Given this list of marker genes TAF12, PBX3, ZNF148, HEXB, TFPI2 (tissue factor pathway inhibitor 2), ID4, INPP5K, CREB1, FOXD1, MYH10, CDK1, KIF11, MGAT2, NIPAL3, ALDH7A1, CDKN1A, CSNK1A1, ABCD3, TUBB, HMGCL (3-hydroxy-3-methylglutaryl-CoA lyase), CTSL, EPCAM, KIF2C, NID1, CD9, HSPA5, KAT5, FGF9, CCNG2, ZNF711, FCGRT, ATP6V0A1, SERPINB1, CD46, CXADR, PLD3, LEPROT, MICB, SRSF3, SEC23A, GALNT3, PGRMC1, KLHDC3, TOP2A, LAMA3, H1-0, RAB6A, PCBD1, MTOR, TMED10P1, GET1, ARF6, EXTL2, PRKAR1A, TM9SF1, PTPN1, PPP6C, RAB8A, CYBA, PTCRA, PPP2R5C, NDUFA4, FSTL1, PPIC, TXNDC9, GTF2I, IGF2R, EXOC5, ACTA2, ANXA7, JAK1, TMBIM6, BNIP3, MAP2K1, ADCYAP1, RDX, IDH1, KIF5B, TMPO, NAT1, CKS2, SERINC3, NDUFS1, NEU1, COPS2, TMED10, DEK, KRT4, NFYC, ATP5PB (NCBI Gene Id 515), MAT2A, RHOC, SRSF5, QPCT, TSG101, NTS, ADD1, CAT, GUCY1B1, TIMM17A, SEPHS2, LUM, KDELR2, TSNAX, ANXA4, CCT7, ZNF43, HAGH, RAB2A, TUBB3, MFGE8, NPC2 (NPC intracellular cholesterol transporter 2), RRAS, CD47, PPP4C, RBM3, HLA-DRB1, SMC1A, NKX2-1, LIPA, GNB1, PICALM, SSR1, MPV17, MEF2C, GSTZ1, GPS2, ID2B, KCNK1, ADD3, UBE2D3, RAB1A, VAMP3, RAB7A, ATXN10, MYL12A, ARPC1A, MAP4K5, TRAM1, SUCLG1, ANXA2, TCEAL1, ADSS2, GATA3, B2M, ITGB3BP, COPS8, NPEPPS, GATD3, CMKLR2, LIMS1, WWP1, TMED2, HMGN4, KIFAP3, CIRBP, CLTB, RAB5B, TM9SF2, ITGA1, NDUFA12, DR1, ECH1, CITED2, H2AC18, ACTR1B, RRM2, PAM, HMGN3, STAT1, MAP2K4, ID2, ZNF267, GNAI1, HMMR, RAB4A, SELENOP, DDOST, KIF2A, H4C14, XIST, PTGR1, ENPP2, IQGAP1 (NCBI Gene Id 8826), AGPS, PRCP, EIF4B, NR3C1, PPP1R1A, HDAC1, SCAMP1, DDX3X, ANXA5, ALCAM, SDHC, TAF11, ANXA1, MLH1, RABGGTB, YBX3, RPS6KA3, here is a description of the gene set: Human Gene Set: WELCSH_BRCA1_TARGETS_UP Loss of function of BRCA1 caused by inherited mutation and tissue-specific somatic mutation leads to breast and ovarian cancer. Nearly all BRCA1 germ-line mutations involve truncation or loss of the C-terminal BRCT transcriptional activation domain, suggesting that transcriptional regulation is a critical function of the wild-type gene. The purpose of this project was to determine whether there is a link between the role of BRCA1 in transcriptional regulation and its role in tumor suppression. We developed a cell line (in which BRCA1 can be induced) and used microarray analysis to compare transcription profiles of epithelial cells with low endogenous levels of BRCA1 vs. transcription profiles of cells with 2-4-fold higher induced levels of expression of BRCA1. At these levels of expression, BRCA1 did not induce apoptosis. Undirected cluster analysis of six paired experiments revealed genes, the expression of which was altered significantly and consistently by BRCA1 induction. Expression of genes was altered more than 2-fold. BRCA1-regulated genes associated with breast tumorigenesis included the estrogen-responsive genes MYC and cyclin D1, which are overexpressed in many breast tumors; STAT1 and JAK1, key components of the cytokine signal transduction pathway; the extracellular matrix protein laminin 3A; ID4, an inhibitor of DNA-binding transcriptional activators, which in turn negatively regulates BRCA1 expression; and the prohormone stanniocalcin, expression of which is lost in breast tumor cells. Coordinated expression of BRCA1 with ID4 and with stanniocalcin was confirmed in primary breast and ovarian tumors. Up-regulated by induction of exogenous BRCA1 in EcR-293 cells species: Homo sapiens from publication Welcsh PL, Lee MK, Gonzalez-Hernandez RM, Black DJ, Mahadevappa M, Swisher EM, Warrington JA, King MC (PMID 12032322)